Given this list of marker genes NRP1, ACVR1, ISL1, BMPR1A, TGFBR2, TGFB2, PARVA, BMPR2, ENG, GATA6, MSX2, ROBO1, RARA, RARB, SEMA3C, TBX1, ZFPM2, SMAD6, NRP2, ROBO2, FGF8, FGFR2, TBX20, TBX2, NKX2-5, SMAD4, LRP2, BMP4 (bone morphogenetic protein 4), here is a description of the gene set: species: Homo sapiens Human Gene Set: GOBP_OUTFLOW_TRACT_SEPTUM_MORPHOGENESIS The process in which the anatomical structures of the outflow tract septum are generated and organized. The outflow tract septum is a partition in the outflow tract.